Given this list of marker genes Tpr, Baz1a, Cdk2, Kmt2a (lysine (K)-specific methyltransferase 2A), Rlf, Phf8, Dyrk1a, Phf2, Dnmt3l, here is a description of the gene set: Any process that modulates the frequency, rate, extent or location of heterochromatin formation. species: Mus musculus Mouse Gene Set: GOBP_REGULATION_OF_HETEROCHROMATIN_FORMATION